Given this list of marker genes Nrbf2, Pik3c3, Uvrag, Becn2, Pik3r4, Atg14, Becn1 (NCBI Gene Id 56208), here is a description of the gene set: studied in species Mus musculus Mouse Gene Set: GOCC_PHOSPHATIDYLINOSITOL_3_KINASE_COMPLEX_CLASS_III A phosphatidylinositol 3-kinase complex that contains a catalytic class III phosphoinositide 3-kinase (PI3K) subunit bound to a regulatory (adaptor) subunit. Additional adaptor proteins may be present. Class III PI3Ks have a substrate specificity restricted to phosphatidylinositol (PI).